Given this list of marker genes Prps1, Paics, Gart, Ppat, Shmt1, Hprt1, Ada, Aprt, here is a description of the gene set: Mouse Gene Set: GOBP_PURINE_NUCLEOBASE_BIOSYNTHETIC_PROCESS The chemical reactions and pathways resulting in the formation of purine nucleobases, one of the two classes of nitrogen-containing ring compounds found in DNA and RNA, which include adenine and guanine. species: Mus musculus